Given this list of marker genes ERF, IHH, HOXD13, MAP3K20, PTHLH, VAC14, ACVR1, FIG4, here is a description of the gene set: Aplasia/Hypoplasia of the phalanges of the hallux Human Gene Set: HP_APLASIA_HYPOPLASIA_OF_THE_PHALANGES_OF_THE_HALLUX studied in species Homo sapiens